Given this list of marker genes UBE2B, ZNF148, SPEM3, MAST2, CFAP69, DDX6, PTX3, EDN1, MSH4, TTLL5, TDRD12, NOTCH1, CADM1, SPIN4, SPATA31A6, ACTL7A, CELF3, SLC2A8, ROPN1B, MNS1, USP42, KRT9, PRKAG1, TESK2, PRDM9, FOXO3, DDX4, HOXA11, CTCFL, H3-3B, GALNT3, ZCWPW1, SPATA31C2, PARN, PTEN, SKA3, ANG, SLC26A8, FOSL1, CHD5, SIX5, DMC1, AFG2A, AXDND1, GMCL1, CBY3, CUL4A (NCBI Gene Id 8451), POC1B, CNBD2, ZMIZ1, TP63, TSSK1B (NCBI Gene Id 83942), ADAMTS16, PLA2G3, UBB (NCBI Gene Id 91253), IFTAP (intraflagellar transport associated protein), ZC3H14, ADAMTS1, SPA17, TXNDC2, BMAL1, WDR33, HSF1, ATP2B4, VIPAS39, DEDD, CCER1, YTHDF2, RIMBP3, ADAM29, TGFB1, NOS3, SMAD4, PROK2, BPY2, ARMC2, KIAA0319L, EED, DUSP13B, PAFAH1B3, CRTAP, KCTD19, CFAP206, MYCBP, ASPM (NCBI Gene Id 93990), CCNB2, BTBD18, ZNF296, CFAP53, NR0B1, SPIRE1, TEX14, AGO4, AR, QKI, TSSK2, CDY2A (chromodomain Y-linked 2A), LEP, SOD1, FIGLA, DPY19L2 (NCBI Gene Id 283417), MORN2, CFAP157, ING2, SPATA16, RAD23B, CFAP54, VDAC3, MFSD14A, GK2, FSIP2, UPF3A, CDK16, TRIM28, MEA1, ADAD1, TDRD1 (tudor domain containing 1), CIB1, NLRP14, UCHL1, NPR2, CFAP119, CCNI, PAFAH1B2, ACE, GMNC, SPACDR, TMF1, ODF2, PLEKHA1, ELL3, CFAP61, NSUN2, IFT27, RXFP2, NUP210L, HADH, PHC2, NPAP1, IGF2R, INHBA, CCNB1, GALNTL5, WDR48, HOXA10, SYCE3, SOS1, ADAM7, H2BC1, PYGO1, NANOS2, CGB7, SPIN2B (spindlin family member 2B), SEBOX, FAM9B, YBX3, BCL2L11, NOBOX, DIRAS3, SYCP2, RNF114, CHN2, ODF1, CATSPER2, ZAR1L, TCFL5, KDM3A, MCM9, SPAG11B, FSHB, CDYL, ATP1A4, JAG2, CELF4, ADGRG2, BCKDK, SPANXA2, AFP, YTHDC2, DNMT3A, PAEP, BAX, HPGD, TCP11X1, BBOF1, WDR77, ARMC12, SEPTIN12, REC114, NEURL1, PMCH, SLC26A6, TNP2, ANKRD49, SSH2, WIPF3, SYNE1, CLDN11, DNHD1, PLD6 (phospholipase D family member 6), TSPY4, WEE2, TMEM119, TTLL1, NEURL4, HSF5, MSH2, ODAD3, NRIP1, KAT5, H1-6, GGNBP2, ITGB1, DCAF13, ARID4A, GAS2, MEIOSIN, ADCYAP1R1, CFAP57, CEP128, NICOL1 (NCBI Gene Id 401115), TTLL3, CCDC159, ACOX1 (NCBI Gene Id 8308), CALR3, RB1, NCAPH, GJA1, SPIRE2 (spire type actin nucleation factor 2), MDK, DAZ4, INHBB, RAB24 (NCBI Gene Id 53917), SOX17, SGPL1, CCNY (NCBI Gene Id 219771), HERC4, AKT1, PCSK4, PGM3, PAX5, BMP15, OOSP2, CATSPER3, FMN2, DZIP1, PRKACA, CCDC136, TRIM27, GHSR, BIRC3, SEPTIN14, GMCL2, TTC21A, RBM46, TDRD5, SPATA31A1, SLC22A16, ZSCAN21, SEPTIN1, ADAMTS2, APOB, SOX30 (NCBI Gene Id 11063), PUM1 (pumilio RNA binding family member 1), MEIOC, TSPAN8, FAM209A, SHISA6, TEX19, TAF1L, DAZ3, KIFC1, KDM2B, NDC80, SLC22A14 (NCBI Gene Id 9389), TOP2A, DLD, CFAP221, KLHL10, FIGNL1, SOX9, GGN, CETN2, WNT4, MKRN2, AKAP4, LZTFL1, SEMG2, SIRT2, NANOS3, TLE6, SPINK1, DMRTC2, SPATA31E1, GORASP2, PDE3A, M1AP, RARA, PAQR8, FAM9C, PIWIL3, COX7B2, SPPL2C (NCBI Gene Id 162540), INSL3, MAJIN, GARIN1A, MYBL1, DAZ1, USP26, RFX2, BSPH1, BBS4, ZBTB16, ACRBP, ADAD2, CFAP65, LSM14B, RSPH6A, CFAP47, KIF18A, CT55, SPATA31D4, PTN, TEX11, KMT2D, FOXJ1, CATSPERE, RGS2, ORC4, TUBA8, SNRPA1, RBMY1B, SPAG17, MYCN, ATRX, ANGPT2, TYRO3, RAN, ZNF830, FAM50A, SPEM1, PSMA8, NKAPL, TBPL1, SLC19A2, NR2C2, YIF1B, TPGS1, TSSK4, TTLL8, SEPTIN4, BPY2B, CGB3, DAZ2, DAZAP1, DEFB1, SEPTIN2, LARP7, CFAP91, LRRC46 (NCBI Gene Id 90506), HOXA9, TXNDC8, KHDRBS1, BCAS2, BCL2L10, TCP11, FXR1, ASF1B, PANK2, TPPP2, ADIG, KASH5, SPATA31A3, LGR4 (leucine rich repeat containing G protein-coupled receptor 4), PAFAH1B1, TTK, WASHC5, FNDC3A, PNLDC1, USP9X, CATSPERZ, TUBB8, VPS13B, BTG1, YY1, CCDC62, TXNRD3, ZDBF2, GJA10, FUT6, CREM, RUVBL1, SELENOF (NCBI Gene Id 9403), MAK, PIWIL4, FOXA3, BRCA2, DHH, PATZ1 (POZ/BTB and AT hook containing zinc finger 1), UBR2, SUN1, TSGA10, PIWIL2, MCIDAS, FER, FOXL2, TSSK3, PRSS21, SPATA31D1, H2AX, H1-7, PAIP2, CDKN1C, FANCD2, TOPAZ1, SPACA1, CEP57, SLC25A31, BOLL, HMGB2, SPIN1, RIMBP3B, LIN28A, TSNAX, DNAH1, HSF2BP, ETV5, PDILT, TNP1, LRGUK, SPATA19, ARRDC5, SPANXB1, CALR, DMRT1, NR5A2, PDCL2, SPATA2, ASZ1, PTGDS, TESMIN, CEP131, ROPN1, CFAP44, IFT56, ABHD2, DND1, BCL2L1, CCDC63, ETV6, JAM2, FANCL, PRM1, SPATA6L, CDC25B, SPMAP2, WT1, CDY1B, SMAD5, MOV10L1, SEMG1, SPATA31C1, ACVR1, CNTLN, SPATA46, TBATA, TRIP13 (NCBI Gene Id 9319), PACRG, RIMBP3C, TSPY2, SPATA25, ZPBP, BMP4, NDRG3, IFT25, SPMIP7, BCL2L2, TCP11X2, UBE2J1, CDY1, SOX8, CTDNEP1 (CTD nuclear envelope phosphatase 1), SPAG6 (NCBI Gene Id 9576), VCX (variable charge X-linked), MTA2, SBF1, LRRK2, C2CD6, HMGA2, CCDC146, ACVR2A, RHBDD1, YTHDC1, CCNO, RNF2, CCR6, PITHD1, CFAP58, SIRT1, ACSBG2, RPS6KB1, TDRP, KIT, PRMT7, MROH2B, STAU2 (NCBI Gene Id 27067), SUFU, CXADR, NME8, PCDH11Y, TSPY9, STK11, FBXW11, MMP2, LHCGR, HERPUD2, PTTG1, FBXO5, TBC1D20, LRRC8A, HOOK1 (NCBI Gene Id 51361), MARF1, DCAF17, MLH1, SPATA31A5 (NCBI Gene Id 727905), ZFY, TOB2, CCNA1, SUN5, NME5, SPATA32, CYLC2, METTL3, DPY19L2P2, SYCP1, PLK1, SPIN2A, TMPRSS12, FANCG, SSX1, TRIM75, PMFBP1, KDM1B, SIAH1, CRKL, DDB1, TSPY8, ZFP57 (ZFP57 zinc finger protein), SPATA31A7, PARP11 (poly(ADP-ribose) polymerase family member 11), PTCH1, TEX15, GGT1, KAT8, SERPINA5, ARID4B, ZMYND12, CATSPER4, FOXJ2, AGFG1, SEPTIN6, IQCF1, CYP26B1, SFMBT1, GSK3A, DRC7, GPX4, SPAG8, SLIRP, IMMP2L, PRKACG, MAEL, FREY1, CELF1, DNALI1, EIF5A2, TMEM232, MGAT4D, SLC9A8, LIMK2, TMEM203, MLH3 (mutL homolog 3), STAU1, PCYT1B, ZNF628, DPCD, BPY2C, PRKG1, EIF4G3, SKIL, SPATA31D3, IQCN, MMP19, BRDT, CTCF, GTSF1, TESK1, NPM2, GAMT, METTL14, SPDYA, PGR, TBP, HOATZ, TTC12, LGR5, IQCG, SOHLH1, MERTK, SPO11, GDF9, RBP4, RSPH1, SYCP3, BCAP31, ROPN1L (NCBI Gene Id 83853), IFT20, SLC9C1, FKBP6, SPIN3, SLCO4C1, TGFBR1, SPINK2, E2F1, DEFB118, FOXC1, NODAL (nodal growth differentiation factor), FSHR, DEAF1, TDRD9, PRDX4, PRDM1, SPOCD1, ERCC1, PIK3CA, NR6A1, ARMC3 (NCBI Gene Id 219681), H1-9P, MSH6, BRD2, HROB, TERB2, CLOCK, AMH, ELSPBP1, SPATA9, CABS1 (calcium binding protein, spermatid associated 1), EDNRA, MCM8, AGFG2, TSSK6, KLC3, SPATA22, SETX, CCNB1IP1, SPMIP6, ZNF541, POC1A, ZFP41, USP9Y (ubiquitin specific peptidase 9 Y-linked), SKA1, SRPK1, OR7C1, FOXJ3, TAF4B, HORMAD1, GARIN1B, DDX3Y, PRM2, DNAAF3, PSME4, RAI14, SCAPER, XRN2, PFN4, SPATC1L, DAZL, C3orf62, CCNYL1, NDC1, GPR149, RAD51C, EIF2S2 (eukaryotic translation initiation factor 2 subunit beta), MEIOB, TNFAIP6, TSPY3, ADAM28, SPATA20, ROS1, ZPBP2, ADGB, TARBP2, H1-1, CIMAP1A, FST, BCL2, RPL39L, CYLC1, FANCA, TSPY10, TBC1D21, TAF7L, DIAPH2, GARIN3, EFCAB9, PANX1, FAM9A, DLEC1, ATAT1, ZAR1, DDX3X, IGF1, SPAG16, C14orf39, SEPTIN7, IGF2, PIAS1, AZIN2, SMAD1, ZNF35, ATM, PAQR7, MASTL, GAL3ST1, CCDC34, REC8, TDRD6, ZSCAN2, SLC4A2, RPS6KA2, DDX20, MKKS, PYGO2, OVOL1, ADAM18, RPL10L, RNF8, SPEF2, RACGAP1, DHX36, MOS, BCL6, HSF2, CCDC38, HPGDS, ACRV1, ZMYND15, SHCBP1L, VPS54, PLN, NANOS1, CATSPERG, SLC2A14, CTSH, OAZ3, KNL1 (NCBI Gene Id 57082), TUT7, PRSS37, STRA8, PIWIL1, NPHP1, ACTL9, CREB3L4, MYCBPAP, TSNAXIP1, BAG6, CSNK2A2, FAM209B, JAM3, GARIN4, CIBAR1, B4GALNT1, PTGDR2, GLI1, H3-4, ODF4, WNT3, PRM3, EREG, BRME1, IHH, GGNBP1, MEIKIN, SKA2, DDX25, INPP5B, PAQR5, TUT4, CATSPERD, PRDM14, SLC26A3, ZGLP1, CATSPER1 (cation channel sperm associated 1), CDY2B, CCIN, ZP3, CAPZA3, AURKA, ZNF449, RBX1, CFTR, DRC1, PPP2R1A, HERC2, CATSPERB, MECP2, HEXB, BMPR1B, AXL, CTNNB1, STRBP, BNC1, YBX2, HSPA2, CABYR, FBXO24, WFDC2, NECTIN2, DYNLL1, RNF151, ATN1, SASS6, PGAM2, NPPC, MTOR, RNF17, SPAG4, MEIG1, ICA1L, MEI4, SSTR1, MCMDC2, PPP1CC, BRIP1, TSPY1 (NCBI Gene Id 87538), MORC1, EPC1, EHMT2, NDN, NCAPH2, CFAP97D1, IZUMO3, ALKBH5, TDRD7, SMARCA2, KATNAL1, SRC (SRC proto-oncogene, non-receptor tyrosine kinase), CCDC87 (NCBI Gene Id 55231), SOHLH2, CCDC42, AP3B1, NTRK1, OSBP2 (oxysterol binding protein 2), CFAP43, DNMT3L, TDRKH, SPATA6, CNTD1, OCA2, STK33, PRSS42P, SPATA24, BBS2, AFF4, ADCY10, UTP14C, SHB, IHO1, H3-3A, SPANXA1, CFAP52, IFT81, here is a description of the gene set: The generation and maintenance of gametes in a multicellular organism. A gamete is a haploid reproductive cell. Human Gene Set: GOBP_GAMETE_GENERATION species: Homo sapiens